Given this list of marker genes Oprd1, Tssk6, Epo, Rps6ka2, Stk39, Tgfbr1, Bax, Tenm1, Crebl2, Agt, Ttbk2, Akt1, Ifng, Plk2, Mtor, Pak2, Camk2d, Mad2l2, Hdac6, Nos1, Mark3, Hipk2, Pkd1, Gadd45a, Syk, Ntrk3, Galnt4, Csnk1a1, Bcl2, Dclk1, Fnip1, Ifnb1, Lrrk2, Tlk2, Tssk4 (NCBI Gene Id 76401), Mapkapk2, Srpk2, Isl1, Trim6, Plk1, Uhmk1, Ercc6 (NCBI Gene Id 319955), Pfn2, Ripk1, Prkdc, Lats1 (large tumor suppressor), Dclk3, Tssk2, Irgm1, Poglut1, Dkk1, Rictor, Brsk1, Stk4, Galnt13, Bdkrb2, Ttk, Mlxipl, Aurka, Prkaca, Rptor, Pck1, Wnt3a, Nck1, Nsd1, Mknk1, Mgat5b, Tnks1bp1, Pak1, Wnt5a, Cnksr3, Poglut3, Galnt3, Cdk5, Bcar3, Fam3c, Ip6k2, Cav1, Grk2 (NCBI Gene Id 11557), Sptbn4, Prkce, Spry2, Camk2a, Map3k13, Egfr, Igtp, Irgm2, Ulk1 (unc-51 like kinase 1), Bdnf, Prkd2, Camk2b, Prkx, Chek2, Cdk5r1, Cdk2, Mapkap1, Atm, Ntmt1, Pikfyve, Top1, Mapk14, Gsk3a, Slc1a1, Prkcd, Fnip2, Epm2a, Pdk3 (NCBI Gene Id 67624), Mif, Hgf, Myo3b, Dock7, Mapkapk3, Prkcz, Brsk2, Ntrk2, Smad7, Rock1, Cnot9, Akap9, Bag4, Ucn, Tfrc, Pbk, Ttbk1, Met, Tssk1, Angpt1, Inpp5k, Akt3, Smg1, Galnt1, Csnk2a1, Clspn, Mapk1, Hrc, Txn1, Stox1 (NCBI Gene Id 216021), Tnf, Tek (TEK receptor tyrosine kinase), App, Inpp5f, Il6, Tnks, Blvra, Paqr3 (NCBI Gene Id 70746), Phip, Prkca, Atr, Map3k10, Mapk8, Akt2, Pdcd10, Raf1, Braf, Dgkq, Park7, Prkaa1, Cdk1, Bak1, Ogt, Mark2, Ntf3, Ripk2, Myo3a, Ppm1f, Lmtk2, Rps6kb1, Rack1, Prkd1, Il11, Cab39, Dmtn, Arrb2, Mboat4, Morc3, Map4k1, Ern1, Eif4g1, Clk1, Galnt16, Ilk, Tbk1, Avp, Gpd1l, Nrxn1, Poglut2, Smyd3, Inpp5j, Galnt2 (polypeptide N-acetylgalactosaminyltransferase 2), Pten, Mapk12, Dclk2, Rassf2, Gsk3b, Smtnl1, Mir301, Map2k2, Ikbke, Araf, Mapk13, Hipk3, Pink1, Nek6, Dyrk1a, Mapk7, Map3k12, Hipk4, Cd44, Ikbkb, Osm, Ret, Lif, here is a description of the gene set: Mouse Gene Set: GOBP_PEPTIDYL_SERINE_MODIFICATION The modification of peptidyl-serine. studied in species Mus musculus